The following is a description of a gene set: part of: Activation of BH3-only proteins The switching on/off of its phosphorylation by growth/survival factors regulates BAD activity. BAD remains sequestered by 14-3-3 scaffold proteins after phosphorylation by Akt1. Calcineurin activates BAD by dephosphorylation. species: Homo sapiens Reactome Pathway: Activation of BAD and translocation to mitochondria, and this is the list of marker genes: YWHAZ, YWHAG, YWHAQ, BCL2, PPP3R1 (protein phosphatase 3 regulatory subunit B, alpha), YWHAE, YWHAH, SFN (NCBI Gene Id 2810), AKT2, AKT1, PPP3CC, BAD, AKT3, YWHAB, BID